The following is a description of a gene set: species: Mus musculus from publication Yevshin I, Sharipov R, Kolmykov S, Kondrakhin Y, Kolpakov F (PMID 30445619) Genes containing one or more binding sites for (Utp3) in their promoter regions (TSS -1000,+100 bp) as identified by GTRD version 20.06 ChIP-seq harmonization. Mouse Gene Set: UTP3_TARGET_GENES, and this is the list of marker genes: Zfp82, H2bc8, Mccc1os, Rnf43, Mrm2, Zfp142, Cibar1, Mrpl51, Ppie, Ing5, Ogg1, Mtg1, Krcc1, Rex1bd, Zfp597, Gm10827, Mtch2, Pfkp, Gga3, Sf3b3, Hpca, Nfs1, Trp53bp2, Dync1i2, Acbd3, Tmco3, Gm16136, Nup85, Abcf1, Cherp, Gm25296, Gm23639, Gpr155, Ncapd2, Tent4a, Pex1, Stxbp4, Mir1938, Prkacb, Gm26330, Epn1, Elof1, Etaa1os, Gm14966, Fbxl5, Xrcc2, Zmat5, Eif3b, Pld2, Lias, Tonsl, Trmt9b, Mphosph6, Tmem167, Mapk14, Sipa1, Pdcd5, Lnpep, Elk4, 1700123M08Rik, 9130604C24Rik, Tcta, Sulf1, Egfl7, Cdc27, Ube2k, Fam43a, Inava, 9330111N05Rik, Sfpq, Smad1, D6Wsu163e, Rpl11, Gm15179, Zbtb21 (zinc finger and BTB domain containing 21), Elp5, Rpl31, Ctdnep1, Hk1os, Mterf4, Snora21, Oser1, a, 1110025M09Rik, Prmt3, Ddx19a, Phkb, Pex7, Kntc1, Kcnq1, Rnls, Chmp6, Ezh2, Frat1, Gm28535, Ankrd44, 2500004C02Rik, Srek1ip1, Ctu2, Gm6410, Adissp, Stag3, Itfg1, Clptm1, Fam98c, Pafah1b3, Ccdc28a, Gm10644, Ntpcr, Bcl7c, Safb2, Eif4a1, Supv3l1 (suppressor of var1, 3-like 1 (S. cerevisiae)), Eif4a3, Atg9a, Unc5a, Zfp866, Naa50, Gm7008, Dap, Ccdc159, 4921522P10Rik, Pnpla8, Agfg1, Carf (calcium response factor), Tmeff1 (NCBI Gene Id 58247, transmembrane protein with EGF-like and two follistatin-like domains 1), AA467197, Tor1aip2, Dhcr7, Klhdc8b, Hspbp1 (NCBI Gene Id 66245), Myo9a, Bbc3, 1110002L01Rik, Ints15, Zbtb45, Cep63, Rnf220, Gm6556, Galnt9, Nup133, Mri1, Slc9a5, Ccn3, Tmem242 (NCBI Gene Id 70544), Mad1l1, Rps19, Rnaseh2c, Nrde2, Gm13267, Asic3, Gm38293, Uqcc4, Gpatch4, Rcn2, Klhl35, Pacs1 (phosphofurin acidic cluster sorting protein 1), Med25, Coq8a, Ccdc148, Aars2, Pgk1, Tbc1d14, Gtf2h1, Vangl2, Supt5, Cnot4, Rps17, Paip2, Gphn, Rasgef1a, Atg16l2, 1700101I19Rik, Znrf1, Tmem79, A130010J15Rik, Xkr6, Rnf166, Drg2, Ctcf, Spag4 (sperm associated antigen 4), Hspa9, 2900093K20Rik (RIKEN cDNA 2900093K20 gene), Cacybp, Erbin, Cyb5rl, Tmem63a, Lpcat2, Rps8, Lysmd1, 1700104B16Rik, Tmem119, Gdap1, Cnpy3, Plec, Hnrnpf (heterogeneous nuclear ribonucleoprotein F), Dnajc1, Gar1, Cfap299, Kmt5a, Gm25268, Zfp672, Mir574, Utp14b, Phip, Ift56 (intraflagellar transport 56), Rbm7 (NCBI Gene Id 67805), Ublcp1, C920006O11Rik, Gm13421, Csnk2a2, Ptprn2, Urgcp, Rprd2, Sdc4, Phf20, Kcnn2, Hus1 (NCBI Gene Id 15574), Lyrm1, Ppia, Fto, Lrrfip1, Ripor1, H2ac15, Gm13034, Wdr83, Sec11a, Carmn, Col4a1, Zfp760 (zinc finger protein 760), Gipc1, Anapc13, Arl8a, Pogk, Akap8, Slc4a3, Srsf2, Cdh23, Klhl22, Eif3i, Dus1l, Gm24016, Anp32e, Aaas, Jpt2, Pold3, Tial1, Ncbp2, Zswim7, Mylip, Rasgef1c, Tmcc2, Ranbp17, Gm10518, Ywhaq, Ssbp1, Ipo8, Senp8, Cyp27a1, Acd, 2810004N23Rik, H2-T7, Prkd3 (NCBI Gene Id 75292), Taf15, Synm, 1700023H06Rik, Prcp, H3c13, Cnga3, Disp2, Lmf1, Epb41l4aos, Hecw2, Tmem186, Smarce1, Irak1, Gm25541, Rubcn, Cfap97, Adgrv1 (NCBI Gene Id 432787), Fastkd1, Cox11, Gtpbp4, Terf2, Naa25, Gm15417, Ncam1, Vta1, Rps20, 1700096K18Rik, Brpf1, Gpr45, Necab2, Homer3, Snhg17, Mrps10, Slc2a4, Gm13136, Uqcr10 (ubiquinol-cytochrome c reductase, complex III subunit X), Ppm1d, Slc7a6, Yap1, Car7, Sf1, Gm26511, B930036N10Rik (RIKEN cDNA B930036N10 gene), Yipf3, Tbc1d1, Zfyve16, Ankhd1 (NCBI Gene Id 74483), Glrx3, Fmc1, Zmiz2, Zc3h18, Gm6723, Bcs1l, Zfp768, Cacna1a, Pi4k2b, Raly, Tbc1d8, Rpl13 (ribosomal protein L13), Golga2, 6030442K20Rik, Ubxn7, Farsa, Tiparp, Zscan10, Shisa7, Nop56, Gabpb2, Card19, Adgra2, Gm9958, Zkscan8, Txndc12, Cyth2, Gpc1, Cenph, Pou2f1, Aldh1a3, Prpf4 (NCBI Gene Id 70052), 1700034H15Rik, Psme1, Glud1, Sephs1, Tab1, Amfr, Map3k20, Arfgap2, Csnk1d, Nufip2, 4732440D04Rik, Ash2l, Pfkl, Arrdc3, Trap1, Prdx1, Mfsd4a, Snora78, Pms2, P2rx3, Rasa1, 4930563E18Rik, Pnkd, Nup188, Rb1cc1, Scg2, Pdia3, Prkag3, Agbl5, Kdsr, Vwa8, Plscr1, Atg7, Mafg, Rbm34, Eif1b, Ufsp2, Snora73a, Fmn1, Plekhm3 (NCBI Gene Id 98354), Piezo2, Eef1a1 (NCBI Gene Id 13627), Stk38, Zfp963, Mir8109, Zfp784, Ppp3cb, Stamos, H3f3b, Thoc6, Mlst8, Chst10, Ighmbp2, Myl4, Uggt1, Hnrnpu, Srd5a3, Znhit1, Pcnx4, Slc35b2, Wdr37, Rrm2b, Rrm1, Tsen15, Ndufaf1 (NADH:ubiquinone oxidoreductase complex assembly factor 1), Dhps, Zfp341, Rabif, Rbm4b, Rack1, Xrcc5, Mrpl37, Pxn, Ccdc146, Sirt6 (NCBI Gene Id 72769), Spata25, Nbeal1, Dot1l, 0610040J01Rik, Tgfb2, Tnpo3, Tsacc, Tyms, Txnl4b, Tbc1d9b, Cdc42bpa, Alkbh3, Bmp7, Midn, Pgap1, Scrt1, Chmp5, Serinc5, Thumpd2, Palb2 (partner and localizer of BRCA2), Ankrd17, D030028A08Rik, Duxf1, Nos1ap (NCBI Gene Id 70729), Vps4a, Ccne2, 4731419I09Rik, Ppp1r26, Smg7, Def8, Emc4, Dubr, Cfap68, Ipo9, Rala, Wdfy1, Nudt1 (nudix hydrolase 1), Sdf4, Otud7b, Med18, Tmco1, Rpl9, Kdm2a, Gabpb1, Eif4a2, Ak6, Gpr176, Cacng2, Mthfd1l, Niban3, Tsc22d4, Faah, Gm9920, Mtmr6 (myotubularin related protein 6), Sec61a2, Trrap, Mul1, Fdxacb1, Ywhae, Atp6v1a, Asah1, Fads6, 2310057M21Rik, Ano6, Lpcat1, Lztr1, Naa38, Ckap2, Mrpl11, Smarcal1, Atp6v1h, Pcdhac1, Fstl5, Rad9b, Scg3, Ptpa, Zfp345, C030037D09Rik, Zc3h13, Hycc2, Gm37885, Heatr6, 1700066J03Rik, Cnot1, 1700030K09Rik, Ndufb3 (NCBI Gene Id 66495), Spdya, Cdk20, Rragd, Ccdc9, Myo1h, 9430091E24Rik, Pank3, Kif20a, Ppp2r3d, Cog4, Cpped1, Pcmtd1, Gm14965, Ino80e, Mlec, Mdm4, Pdp1, Il17ra, Coa5, Desi2, Gpc2, Samhd1, 4930532G15Rik, Sass6, 5330413P13Rik (RIKEN cDNA 5330413P13 gene), N6amt1 (N-6 adenine-specific DNA methyltransferase 1 (putative)), Snord55, Med4, Kxd1, Snhg3, Dbr1, Kansl3, Gm22589, Dguok, Tor1aip1, Ep300, Snord110, Mir7075, Ptp4a1, Mettl16, Laptm4a, Fam149b, Ap1s1, Odr4, Esco1, Anxa2r2, Yars1, Dctd, Gm9903, Acss2, Ppp4r3a, Zfp335os, Cep41, Ttc39d, Gm26590, Usp48, Hacl1 (2-hydroxyacyl-CoA lyase 1), Snord60, Ddx39b, Mcm8, Ndufs1, Gm23969, Pard3, Fra10ac1, Slc16a9, Zzz3, Ddx19b, Ywhaz, Mymx, Yjefn3, Tra2b, Kctd15, H4c14, Pmvk, Zfp998, Ccdc93, Mpz (myelin protein zero), Serbp1, Map7, Ahi1, Snx18, Irf8, Hdlbp, Rundc3a, Tmem14a, Brd9, Tardbp, Cic, Srp19, Tbl1xr1 (NCBI Gene Id 99912), Ikzf3, Myd88, Timm23, Gm28417, Asxl1, Adgrl2, Glis3, Zfp668, Lefty2, Stxbp5l, Pym1, Surf6, Rps19bp1, Epb41l4b, Ndufs7, Tcf4, Safb, Pdik1l, Zmat3, Arhgef7, Emg1, Fam131a, Mrpl21, Rbbp5 (retinoblastoma binding protein 5, histone lysine methyltransferase complex subunit), Cdkl2, Ddias, Dcbld1, Exosc4, Adam5, Rpl26, Zfp180, Ppp1r12b, Dnaja2, Hdac10, Gpx1, Sorbs2, Qsox1, Marchf8 (NCBI Gene Id 71779), Aatf, Wdr12, Cux2, Aldh9a1, Klhdc9, Ppp4r3b, Map4k5, Mettl3, Pa2g4, Romo1, Tenm3, Ctsl, Apba2, Cwc27, Zfp770, Zfp652os, Prpf8, Lrrc75a, Gm9929, Ppp1r8, Pop7, Snord49a, Ranbp1, Fnta, 6820431F20Rik, Snapc5, Gm27003, Syt14, Mapkapk5, Lysmd2, Uchl3, Edc4, Tcea1, Polr1c, Cfap96, Gm7461, 2310001K24Rik, Ino80, Ifrd1, Utp4, Ddost, Actr3, Nme7, Rnf121, Alad, Fam53b, Stk11ip, Irf6, Nrm, Knl1, Zc3h6, 2410006H16Rik, Sgms1, Ccdc102a, Ppp1cb, Adamts14, Usb1, Phlda3, Cd2bp2, Fam221a, Fam98b, Irak2, Rwdd4a, Mtx3, Scnm1, Tlr1, Rita1, Tradd, Mrpl32, Amer3, Rsl1, Tmem68, Thap11 (NCBI Gene Id 76841), Rfc4, Hirip3, Gm5134, Trmt1l, Rhoa, Pabpc1, Borcs8, Nr2c2ap, Tmem179, Dync1li2, Dtl, Nxpe3, Mir7666, Sh3glb1, Gm10638, Trmt10c, Mettl4, Sfi1, Srebf1, Jtb, Sirt1, Gins3, Ucp1, Polg, Cenps, Snx5, Lonp2, Rbm39 (RNA binding motif protein 39), Sav1, Stoml2, Spcs1, S100pbp, Cog2, Ptpn14, Pole3, Atad2b, Amn1, Vamp4, Cxcl3, Rnf10, Ccdc158, Kidins220, Spata31e2, Sh3pxd2b, Gm6712, 4930439D14Rik, Gm4419, Slc30a2, Rnu7, Eps15, Cage1, Arhgdia, Upf3a, Adsl, Prkcz, Phaf1, Stau1, Zer1, Fbxl8, Sf3b1, Krtap28-13, Usp8, Cacng3, D230022J07Rik, Rbm47, Bspry (NCBI Gene Id 192120), Mir762, Zbtb7b, Pdf, Zfp985, Srsf7, Scap, Srsf10, Rpl27, Bag1, Snord2, Ngdn, Inf2, Bcat1, 1810062O18Rik, Gm10308, Unc80, Grb10, Rsf1, A330048O09Rik, Uhrf2, Tti2, H1f3, Unc50, Polr1h (RNA polymerase I subunit H), A430105J06Rik (RIKEN cDNA A430105J06 gene), Top1, Zc3h7a, AU041133, Zcchc14, Chmp1a, Etfbkmt, Hnrnpm, Sumo1, Napg, Zc3h11a, Jpt1 (NCBI Gene Id 15374), Nfyb, Ccdc88a, Gprin1 (G protein-regulated inducer of neurite outgrowth 1), Wdr83os, Pam, Cdin1, Atp13a1, Ncald, Adra2a, Gm13483, Parg, Traip, Boll, Rad17, Palld, Vgll4, Zfp451, Fitm2, Gm14494, Eya1, Ndufaf8, Dynlrb1, Vps36, Dcaf11, Mplkipl1, Gm26812, Sdhc, Fyttd1 (forty-two-three domain containing 1), Bcl6, Pkp2, Ighv1-67, Tepsin, Prkrip1, Marchf4, Usp40, Amz2, Eif4e2, Blzf1, Dcun1d2, Cdk5r2, Nmbr, Rpgrip1l, H2ac8, Zbtb7a, Pard6a, Snord58b, Gm9884, Snord68, Adprs, Hcfc1r1, Dmrtc2, Mir5132, Hmox1, Gm5113, U2af1l4, Sgk1, Septin8, Gnpat, Hps5, Rpl23, Zfp319, Fa2h, Gm29257 (NCBI Gene Id 638636), 6230400D17Rik, Btd, Timm44, Adora1, Fam133b, A830008E24Rik, Mir1894, Enc1, Tars1, Swt1 (NCBI Gene Id 66875), Stam, Gls, Ube3d, Psmd1, Cyrib, Banf1, Rasd2, Mrps28, Hint1, Swi5 (SWI5 recombination repair homolog (yeast)), Pi4ka, Rps27l, B9d2, Dhx29, Zranb3, Ints5, Yars2, Arhgap19, Adnp, Rfxank, Drd4, Prag1, Zfp628, Zfp609, Ubr2, Ppp1r9a, Rnf227, Nmral1, Rab8a, Psmc3ip, Wdr38, Pask, Kif26b, Cep170, Mir212, Taf9, 4632415L05Rik, Syce2, Brme1, Snx25, Gabarapl2, Zfpm1, Atl1, Arhgap1, Ndufa12, Mcat, Rps5, Pigw, Zfp383, Gpr35, Rpl6, Vps29, Rft1, Pex5, Zfp882, Tinf2, Dcaf12, Grcc10, Snap29, Commd9, Ubqln1 (ubiquilin 1), Alg9, Asf1b, Lyrm9, Lsr, Zbtb38, B230112G18Rik, Atf6, Irs2, Crat, Birc6, Topors, Mars1, Coq3, Plekhh1, Plod3, A730061H03Rik, Zfyve1, Rpl7, Hsp90aa1, Lrp11, Rnpepl1, Eef1b2, Fem1a, Mrps14, Spata33, 1110035H17Rik, Zdhhc12, Rab13, Cdk5rap3, Mef2a, G430095P16Rik, Rbm25, Btf3l4, Sucla2, Cbr4, Ripk1, Snhg12, 4933430I17Rik, Ints14, Ankzf1, Prmt9, Insig1, 4930519P11Rik, Gm13135, Tpr, Mapk1ip1l, Mmgt2 (membrane magnesium transporter 2), Snx15, Mmadhc, Nr5a2, Rpe, Rpl7a, Glra1, Zmynd19, Ttc19, Med22, Cfap298, Mir132, Nbn, Nt5m, 1700066M21Rik, H2bc15, Gm15634, Efcab7, Cnnm1, Map3k9, Gm26205, Urb1, Sema3a (sema domain, immunoglobulin domain (Ig), short basic domain, secreted, (semaphorin) 3A), Zfp652, Zfp207, Exoc3, Hcfc2, Gm23301, Psma2, Tmem80, Zfp948 (zinc finger protein 948), Sprtn, Ints8, Pus7, Mrpl12, Cript, Mbtd1, Trmt2a, Ppp1r14b, Serpinb6a, Rps27, Alg8, 2700099C18Rik (RIKEN cDNA 2700099C18 gene), Cers4, Mgme1, Tmem183a, Polr3b, Acaa1a, Ndor1, Fbxo33, Mphosph9, Zfp612 (zinc finger protein 612), Dolk, Dennd1b, Dcaf8, Zfp729a (zinc finger protein 729a), Nrxn2, Trappc11 (NCBI Gene Id 97497), Relb, Rpl18a, Ndufa13, Zfp560, Polr3e, Ubiad1, Nol7, Dnajb12, Dnajb2, Maneal (NCBI Gene Id 215090), Dlgap4, Ercc6 (excision repair cross-complementing rodent repair deficiency, complementation group 6), Gsta4, Tcf12, Aldh3a2, Traf7, Mettl25b, Svbp, 1700042O10Rik, Zfp408, Zfp960, Itm2c, Mccc1, Gpat4, BB557941, Arid5a, Aggf1, Actr1b, Kcnt2, Cyb5d1, Unc13a (unc-13 homolog A), Taco1os, Tbc1d9, Msi2, Rbm48, Asxl2, Tnks, Etv4, Catip, Hnrnpk, Pemt, Hnrnph1, Mtbp, Snora26, Actb, Cln8, Tipin, Dusp1, Atxn2l, Mark2, Prr5, Ralgps2, 9230116N13Rik, Mir5627, Psmd3, Rhot1, Ptpn3, Tuba4a, Ppp2r2d, 5430416N02Rik, Lgals8, Fis1, Zfp146, Matr3, Phb2, Tob2, Gm38250, Adgrb3, Mir375, Tm2d3, Mettl21a, Insr, Acads (acyl-Coenzyme A dehydrogenase, short chain), Atp6v0d1, Arhgap12, Wdr45b, E330040D14Rik, Socs1 (suppressor of cytokine signaling 1), Stard3nl, Nt5c3b, Relt, Nabp2, Haus6, Tut7, Polr1has, B230208H11Rik, H4c12, Snord49b, Tlk2, Adipor1, Zfp646 (NCBI Gene Id 233905), Zfp629, Sertad4, Trmt13, Fam187b, Akap10, Ap3s2, Ccdc18, Pbx4, Hk1, Oip5os1, Cdc16, Naa60, Agk, Luzp1, Cpne4, 1700052K11Rik, Atp1b1, Nox4, Gm15418, Trmt6, Pnisr, Cox16, Usp22, Rbm33, Cdiptos, Cfap65, Mir8112, Tnpo1, Smap2, Snord13, Washc3, Parp6, Galnt11, Gli3, B230219D22Rik, Arid3b, Zfp36l1-ps, Gm21182, Haspin, D330050G23Rik, Zcchc8, Socs5, 1700003G18Rik, Cyb5r4, 4930449E01Rik, Tsn, Arhgap22, Clcn3 (chloride channel, voltage-sensitive 3), Gm26608, Gm16023, Gtpbp3, Uba6, Wdtc1, Mrpl44, Efhc1, Bscl2, Dcun1d3, Ap1g1, Pbk, Ddx54, Mir718, Sigmar1, Abhd3, Ect2l, Slitrk5, Dnajb9, Vps35, Gdpd1, 4933424G06Rik, Osbpl3, Sptb, Myo19, Ttc14, Catsper2, Pik3c2b, Papola, Ssrp1, 5430400D12Rik, Arg2, Slc25a12, Ptpre, Alkbh7, Stx7, Cilk1, Nuf2, Coq5, Kit, Polr1b, Sin3b, Kcnh1, Rps2, Gramd1b, 1700086O06Rik, Dab2, Cct3, Galt, Tmem70, Pdlim7, Mkrn3, Auh, Arf6, Ccnj, Psma6, Ikbkb, Hmgn2, Klhdc4, Acsl3, Slbp, B3gnt2, Ldhal6b, Yif1a, Chtf8, Arhgef12, Mfsd11, Pacc1, Zc3h3, Aamdc, Rps6 (ribosomal protein S6), Rpl34, Rasa3, Lpcat3, Epc2, Smim8, Zfp947, Rrp1, Rmi1, Cnr1, Dusp23, Tacc1, Sfmbt1, Rab26os, Mrpl58, Ttc9, Kmt2d, Rsrc2, 2610005L07Rik, Zfp11, Csrp1, Itgb3bp, Tmem165, Tmem169, Rab3gap2, Ocel1, Smim19, Syf2, Mir7b, Klhl10, Hlcs, Xntrpc, Exoc8 (exocyst complex component 8), Ncbp2as2, Btf3-ps11, Ccdc3, Asns, Ehbp1, 1700034P13Rik, Fignl1, Eif1ad, Med9os, Clgn, Tmem203, Mob4, Mtrfr, Atxn7l1, Aacs, Wsb1, Cnpy1, Dis3l, Pecr, Maml1, Oaz1, Wtap, Mnt, Prpsap1, Cnot2, Mpc2, Cops4, Scp2, Sdc2, Ercc2, Gm22711, Thap3, Eif5, Myorg, Rad51ap1, Dedd, Mir9-3hg, Zfp455, Arfgap1, Tsc22d1, U2af1, Mrpl13, Mtus2, Cc2d1a, Sh3rf1, Gm13162, Gm16208, Mast3, Crls1, Wbp4, Psenen, Neo1, Tmed5, Mir1949, Znrf3, Igsf9, Sdccag8, Xrcc4, Cyp51, Ptpn12, Ago3, Cnot8, Wdhd1, Taco1, Rcc1, H3c7, Sys1, Tut1 (NCBI Gene Id 70044), R3hdm1, Wwp1, Deaf1, Amdhd2, Mrps7, Urb2 (URB2 ribosome biogenesis 2 homolog (S. cerevisiae)), Sec13, Gm34767, Dpy19l4, Ppp2r5a, Smim14, Rbbp9, Itfg2, Dctn5, Trim36, Fbxo7, Nup93, Tbc1d13, H2bc18, Ell2, Map4, Kat8, Dync2i2, Mcm4, Zc3h14, Cux1, Brf2, Tmed3 (transmembrane p24 trafficking protein 3), Cdipt, Ap1m1, Cirbp, Rrp15, Anapc7, Lypd4, Pgap3, Gtf2e2, Schip1 (schwannomin interacting protein 1), Vps72, Socs4, 1700067G17Rik, Barhl1, Dcaf6, Cited2, Slc16a14, Abl2, Tgs1, Fam53a, Snora16a, Ggt7, Tex30, Pkp4, 1110004F10Rik, Dhx38, Abcb4, Taf10, Cbfb, Agtrap, Zfx, Marveld3, Acyp2, Gcc2, Eprs1, Aunip, Tmem129, Gtpbp6, Cacna1h, Pde8a, Aldoa, Slc35a1, Dsn1, Ahctf1, 4930555B11Rik, Stat1, Pmm2, Pde4c, Calm2, Xndc1, Cdk11b, Scfd1, Ddx4, Prkdc, Zfp644, Pnldc1, Gm18036, Nuak2, Fbxl17, Keap1, Nubp1, Nek1, Rnu11 (NCBI Gene Id 791078), 1700018A14Rik, Rnf38, Ficd, Polr2a, Cep128, Gm13241, Zdhhc17, Gtpbp2, Riok1, Usp38, Fam114a1, Dipk1b, Fuz, 1500002F19Rik, Tmem234, Polr2m, Vcpip1 (valosin containing protein (p97)/p47 complex interacting protein 1), Ecd, Nppb, Afg3l1 (AFG3-like AAA ATPase 1), Efcab12, Gm9530, Aldh2